The following is a description of a gene set: Genes predicted to be targets of miRBase v22 microRNA hsa-miR-653-3p in miRDB v6.0 with MirTarget v4 prediction scores > 80 (high confidence targets). species: Homo sapiens from publication Chen Y, Wang X (PMID 31504780) Human Gene Set: MIR653_3P, and this is the list of marker genes: TTLL6, SAMD4A, TSPAN5, TAF2, TMEM26, NECTIN3, ATP13A3, CERS6, HERC1, DR1, TRAF3, MINDY2, FAF2, NR3C1, TANK, OTULINL, ANGPTL7, TTC39C, SELL, C5orf22, PURA, PTPN20, IRF1 (NCBI Gene Id 96501), ZBTB7A, PAQR8, RNF8, MATR3, MTAP, FAM133A, STEAP2, NFAT5, ITPRID2, POMGNT2, ITGAX, MAP1B, AEBP2, ESRRG, TMED4, PARN, GABBR1, AGXT2 (alanine--glyoxylate aminotransferase 2), TMCC3, IRF8, SYNRG (synergin gamma), HOXA9, OMG (oligodendrocyte myelin glycoprotein), RASA1 (NCBI Gene Id 5921), ULK2, SLC17A3, NOD2, RPE, DENND1B, AGO3, PHACTR2, GNG5, TOMM20, RFX3, ZNF329, AHSA2P, FAM20C, SETX, SNX31, PRKCH, TIPARP (NCBI Gene Id 25976), RPS3, ROCK2, SPTBN1, CKS2, WDR26, STAG2, YIPF6, ABTB3, YIPF4, XPNPEP1, POPDC3, NEGR1, YWHAG, ZNF74, PLCB1, MBD6, CNTD1, TMEM47, PRKAR1A, VEZT, PSMF1, TOX4, ZIM3, ZNF551, FGF5, MAP3K20, ASF1A, HRH4, PAN3, PRICKLE2, UBTD2, ALDH1L2, EPGN, CNKSR2, PAPOLG, KCTD16, ZNF773, ONECUT2, CCT6A, EML4, FBXL5, KICS2, HPRT1, ENOPH1, PTPRG, NOL4L, LACC1, TMEM170B, CREBL2, HMGCR, BRD8, PHC3 (NCBI Gene Id 80012), PFKFB1, DOCK10, EZH2, ROR1, ANKRD44 (ankyrin repeat domain 44), ACADM, VAT1L, RNF6, ZDHHC17, ERP29 (NCBI Gene Id 10961), SUB1, MAMDC2, PRDM8 (PR/SET domain 8), SLC4A4, FGF9, PRKAG2, KCNH5, NCOA6, PTPRE, NEXMIF, PLCXD3, FAHD1, LINC02873